The following is a description of a gene set: Human Gene Set: REACTOME_FACTORS_INVOLVED_IN_MEGAKARYOCYTE_DEVELOPMENT_AND_PLATELET_PRODUCTION Factors involved in megakaryocyte development and platelet production species: Homo sapiens, and this is the list of marker genes: PHF21A, DOCK8, CABLES2, KIF2B, DOCK11, GATA5, IFNA5, RBSN, H3C1, IFNA17, RAC1, PRKACG, PRKACA, DOCK3, KIFC2, H3-3B, IRF2, IFNA7, IFNA16, KIF4B, CARMIL1, CAPZB, PRKAR1B, TUBA3C, GATA4, TUBAL3, KIF5B, KIF26B, DOCK6, H3C6, IFNA13, KIF2C, IFNA14, MYB, DOCK5, KIF21B, GATA2, GATA1, ZFPM2, H3C13, H3C7, KIF2A, KIF1A (NCBI Gene Id 654843), PRKAR1A, IFNA10, ACTB, MFN1, HBE1, KIF3A, GATA6, H3C14, IFNA8 (interferon alpha 8), TUBA3D, KIF11, KIF21A (NCBI Gene Id 80819, kinesin family member 21A), TUBB6 (tubulin beta 6 class V), TUBA8, KIF22, CBX5, HMG20B, KIFC1 (kinesin family member C1), TUBB2B, MICAL1, IFNB1, TUBB2A, PRKACB, KLC1, KIF1B, KLC2, H3C10, MAFG, DOCK1, H3C12, KLC3, KDM1A, RACGAP1, SIN3A, DOCK2, KIF18B, MFN2, TUBB4A, KIF5A, VPS45, H3C15 (H3 clustered histone 15), HBG1, IFNA1, JAK2, CDC42, CDK2, IRF1, KIF27, H3C3, H3C11, KIF13B, AKAP1, RAB5A, PRKAR2A, CAPZA2, DOCK7, HDAC1, KIF16B, IFNA21, TUBB8B, GATA3, KIF25, KIF3B, IFNA4, KIF18A, KIF15, DOCK10, DOCK9, EHD2, ZFPM1, TUBB8, PRKAR2B, HDAC2, WEE1, SH2B2, KIF4A, TUBA1A, IFNA6, CABLES1, AKAP10, HBG2, EHD1, KIF26A, TP53, KIF20A, CENPE, KIF23, RAD51C (RAD51 paralog C), HBD, MAFF, TUBA1B, RAD51B, KIF3C, KIF12, KIF19, H3C8, KLC4, AK3, H3C2, ITPK1, TUBB3 (tubulin beta 3 class III), TUBA4A, KIF9, TUBA4B, DOCK4, TUBB1, RCOR1, TUBB4B, SH2B3, CDK5 (NCBI Gene Id 1020), H3-3A, TUBA1C (NCBI Gene Id 84790), NFE2, H3C4, IFNA2, KIF20B, SH2B1, ABL1, MAFK, EHD3, JMJD1C, TUBA3E, KIF6, HBB, KIF1C, CAPZA1, KIFAP3